The following is a description of a gene set: Mouse Gene Set: GOBP_REGULATION_OF_CORTISOL_BIOSYNTHETIC_PROCESS studied in species Mus musculus Any process that modulates the frequency, rate or extent of cortisol biosynthetic process., and this is the list of marker genes: Rest, H6pd, Bmp5, Dgkq, Dkk3, Bmp2, Wnt4